The following is a description of a gene set: Human Gene Set: TAKEDA_TARGETS_OF_NUP98_HOXA9_FUSION_3D_UP NUP98-HOXA9, the chimeric protein resulting from the t(7;11)(p15;p15) chromosomal translocation, is a prototype of several NUP98 fusions that occur in myelodysplastic syndromes and acute myeloid leukemia. We examined its effect on differentiation, proliferation, and gene expression in primary human CD34+ hematopoietic cells. Colony-forming cell (CFC) assays in semisolid medium combined with morphologic examination and flow cytometric immunophenotyping revealed that NUP98-HOXA9 increased the numbers of erythroid precursors and impaired both myeloid and erythroid differentiation. In continuous liquid culture, cells transduced with NUP98-HOXA9 exhibited a biphasic growth curve with initial growth inhibition followed by enhanced long-term proliferation, suggesting an increase in the numbers of primitive self-renewing cells. This was confirmed by a dramatic increase in the numbers of long-term culture-initiating cells, the most primitive hematopoietic cells detectable in vitro. To understand the molecular mechanisms underlying the effects of NUP98-HOXA9 on hematopoietic cell proliferation and differentiation, oligonucleotide microarray analysis was done at several time points over 16 days, starting at 6 hours posttransduction. The early growth suppression was preceded by up-regulation of IFNbeta1 and accompanied by marked up-regulation of IFN-induced genes, peaking at 3 days posttransduction. In contrast, oncogenes such as homeobox transcription factors, FLT3, KIT, and WT1 peaked at 8 days or beyond, coinciding with increased proliferation. In addition, several putative tumor suppressors and genes associated with hematopoietic differentiation were repressed at later time points. These findings provide a comprehensive picture of the changes in proliferation, differentiation, and global gene expression that underlie the leukemic transformation of human hematopoietic cells by NUP98-HOXA9. Genes up-regulated in CD34+ hematopoetic cells by expression of NUP98-HOXA9 fusion off a retroviral vector at 3 days after transduction. from publication Takeda A, Goolsby C, Yaseen NR (PMID 16818636) species: Homo sapiens, and this is the list of marker genes: CTSG, CLSTN3, S100A10, SP110, SPINK2, BST2, HEY1, CDKN1C (cyclin dependent kinase inhibitor 1C), PLA2G4A, BISPR, EPSTI1, JCHAIN, VNN1 (vanin 1), PDE1C, XAF1, CYP1A1, IRF9, OFD1, SCN2A, HOXA7, MECOM, REN, HELZ2, RIGI, ADRB1, CLEC2B, RHOBTB1, GLYATL2, IFIH1, RSAD2, PDE3A, IFI6, ERMAP, ARHGAP22, SLC9A7, GBP1, HLX, IRF7, APLF, PARP9, TXK, PARP12, NCOA7, LOX, DMXL2, GBP3, HOXB-AS3, ISG15, IFI35, SDSL, SAMD9L, PTPN13, MEIS1, STAT2, ACSM3, ATP1B1, ANGPT2, SERPING1, OAS3, MLLT3, PCDH9, CARINH, ST6GALNAC1, TCN1, DDX60L, PARP10, IRX3, TTC28, MAP7, HERC6, CRHBP, KIAA0513, PRSS23, GALNT2, IGFBP4, VMP1, TRIM22 (tripartite motif containing 22), MYCT1, NFAT5, AUTS2, BEND6, OSBPL6, KLF5, CRISP3, TOX, IFI16, MALAT1, ERG, IFI44L, PBX3, PTGS1, NEAT1, H2AC6, CAV1, LINC02604, PHACTR4, FCRL4, IFI44, CREBRF, MX1, DTX3L, OAS2, MYCN, RNASE6, RPS6KA5 (ribosomal protein S6 kinase A5), CRISP2, EIF2AK2, OAS1, TRIM9, ZNF503, CD69, LGALS3BP, DDX60 (DExD/H-box helicase 60), HOXA3, TSLP, SLC27A6, GMPR, STAT1, FREM1, BAMBI, HOXA5, USP18, RTN1, FRAS1, IFIT1 (NCBI Gene Id 8374), C3orf80, ALDH1A1, RAB27B, OLFM3, IFIT3, SHFL, CMPK2, RNF213, MX2, NEGR1, ARID5B, TRIM25, COL24A1, PTGER3, MVP, ZBTB20, ARHGEF3, IFIT2, SOX4, HOPX, SLC5A3 (solute carrier family 5 member 3), OASL, IGHM, FGF18, CXCL10, HOXA9, GUCY1A1, LY6E, DST, CCL18, HOXB3, EVI2A, ITGB8, CCDC71L, SLC12A8, PTPRD, BMP2K, CH25H, IFIT5, HOXA6, PARP14, RBPMS, INPP4B, IFITM1, SCN9A, PTGS2, IDO1, ARRDC4, HERC5, IFI27, CELA2B, KIF13A, QPRT, ANGPT1, SAMD9, AHR, NKAIN2, MTCL1